Given this list of marker genes FGFR4, NAA11, NKX2-2, KCNK2, TPI1, CCN5, HSPA5, ISG20, YJEFN3, GALNT14, ZBTB32, SCRT1 (scratch family transcriptional repressor 1), HCN4, FGF22, TBX5, KBTBD13, WTIP, KLHL1, SSR1, TMEM72, SLC22A4, EGF, ARHGAP36, NUP210L, FITM1, SLC22A13, LCAT, CPQ (NCBI Gene Id 51670), ADM, IL36G, FUT7, MIR485, ZDHHC11, CADPS2, LRFN3, DYSF, KCNK12, CHDH, FFAR3 (free fatty acid receptor 3), GAREM1, NPHP3, MMEL1, NAT1, VSTM2B, SPINK6 (NCBI Gene Id 404203), CDH7, CARMIL3, PLS1, UPRT, HMOX1 (heme oxygenase 1), EGFR, CASP3, OXTR, RCAN2, IL7, SDC4, SCN4B, KLF5, HOXB3, PIK3AP1, PNMA2, AWAT2, CGA, PGK1 (phosphoglycerate kinase 1), DYNLL1, SRY, MESP2, CELA3B, WFDC13, YIPF7, CAPZA2, PHLDA1, IL1R1, CXCL3, CABP5, TPD52, LPL, IL12A, PLIN5, ADAMTSL2, PDE5A, LMCD1, S100A8, MIR222, FREM2, TNFSF18, MIR196B, NEU2, ATP6V1G3, CHRM5, KLHL29, DDN, GPR156, GGT1, ZFYVE9, CPNE2, SEZ6L, ERO1B (endoplasmic reticulum oxidoreductase 1 beta), MEP1B, SRPX, IL36A (NCBI Gene Id 83004), SLC6A16, PTH2 (parathyroid hormone 2), PACRG, DSCAML1, GJC1, AK9, RPL39L, MYH1, VSIG2, LRRC30, CDRT4, CXCR4, STT3A, PLB1, MGAT3, RAP2B, DEPDC1, OBSCN, PSMB11, CYP51A1, PLP1, FAM131C, MYO1C, GPIHBP1, TRIM29 (tripartite motif containing 29, NCBI Gene Id 23650), UNC45B, MAGEA10, JAG1, SPCS3, LELP1, PALB2 (partner and localizer of BRCA2), here is a description of the gene set: Genes down-regulated in mature dendritic cells: stimulatory versus inhibitory infected with L. monocytogenes. Human Gene Set: GSE9946_MATURE_STIMULATORY_VS_LISTERIA_INF_MATURE_DC_DN Myeloid dendritic cells (DC) and macrophages play an important role in pathogen sensing and antimicrobial defense. Recently we demonstrated that infection of human DC with intracellular bacterium Listeria monocytogenes (L.monocytogenes) leads to the induction of the immunoinhibitory enzyme indoleamine 2,3-dioxygenase (Popov et al., J Clin Invest, 2006), while in the previous studies L.monocytogenes infection was associated with a rather stimulatory DC phenotype. To clarify this discrepancy we performed comparative microarray analysis of immature mo-DC (immDC), mature stimulatory mo-DC (matDC) and mature inhibitory DC either stimulated with prostaglandin E2 (PGE2-DC) or infected with L.monocytogenes (infDC). Studying infection of human myeloid DC with Listeria monocytogenes, we found out, that infected DC are modified by the pathogen to express multiple inhibitory molecules, including indoleamine 2,3-dioxygenase (IDO), cyclooxygenase-2, interleukin 10 and CD25, which acts on DC as IL-2 scavenger. All these inhibitory molecules, expressed on regulatory DC (DCreg), are strictly TNF-dependent and are in concert suppressing T-cell responses. Moreover, only DCreg can efficiently control the number of intracellular listeria, mostly by IDO-mediated mechanisms and by other factors, remaining to be identified. Analyzing publicly acessible data of transcriptional changes in DC and macrophages, infected by various pathogens and parasites (GEO, GSE360), we noticed that infection of these cells with Mycobacterium tuberculosis causes transcriptional response, comparable with the one caused by listeria in human DC. In fact, granuloma in tuberculosis and listeriosis in vivo are enriched for myeloid DC and macrophages characterized by regulatory phenotype. In summary, regulatory myeloid DC and macrophages may play a dual role during life-threatening granulomatous infections, such as tuberculosis: on one hand, regulatory myeloid cells promote pathogen containment by efficiently killing intracellular bacteria, on the other hand these cells inhibit granuloma-associated T cells and thereby might be involved in the retention of TNF-controlled granuloma integrity protecting the host from granuloma break-down and pathogen dissemination. studied in species Homo sapiens from publication Popov A, Driesen J, Abdullah Z, Wickenhauser C, Beyer M, Debey-Pascher S, Saric T, Kummer S, Takikawa O, Domann E, Chakraborty T, Krönke M, Utermöhlen O, Schultze JL (PMID 18802101)